The following is a description of a gene set: from publication Ochiai K, Maienschein-Cline M, Simonetti G, Chen J, Rosenthal R, Brink R, Chong AS, Klein U, Dinner AR, Singh H, Sciammas R (PMID 23684984) studied in species Homo sapiens Human Gene Set: GSE46606_UNSTIM_VS_CD40L_IL2_IL5_3DAY_STIMULATED_IRF4_KO_BCELL_DN Temporal analysis of B cell activation in vitro using CD40L and IL-2/4/5 cytokines in wild type Irf4+/+ B cells or in mutant Irf4-/- B cells harboring a tet-inducible allele of Irf4. IRF4 expression was restored, or not, in the Irf4-/- background by culturing in the presence of low or high concentrations of doxycycline. The results provide insight in the role of IRF4 expression levels in coordinating different programs of B cell differentiation. Genes down-regulated in at day 0 B cell IRF4-KO versus CD40L and IL-2 IL-4 IL-5 stimulated at day 3 B cell IRF4-KO., and this is the list of marker genes: TMPRSS12 (NCBI Gene Id 283471), LIPI, TFAM, RRP1B (NCBI Gene Id 23076), CTTNBP2NL, INTS7, RUNX1T1, NFX1, FMR1, DDX10, EFR3A, DICER1, DBR1, FUT4 (fucosyltransferase 4), TRIM69, ITPRID2, ZNF496, CCNT2, TFEC, BOD1, INTS12, PARP12, YBX1, ATF5, MICB, IFIT3, RLIG1, ZCCHC2, KLF11, TRIM47, G3BP1, TBRG4, TRIP13, SLC35F2, AIRIM (NCBI Gene Id 54955), COG6, MMACHC, GCNT2, MREG, MMAA, CERT1 (NCBI Gene Id 10087), ERH, NOL10, LRRC69, LRRC40, CNDP2 (NCBI Gene Id 55748), SLC35A4, KICS2, RPP40, ZNF571, MTX3 (metaxin 3), ICE1, ZNFX1 (zinc finger NFX1-type containing 1), TOP3A, IFI27, RASA1, NEXN, IRF9, ADPRS, DTX3L, OTUD4, IFI35, RRP7A, FHIP2A, AP1AR (NCBI Gene Id 55435), ZNF565, ZNF343, MAK, CEP83, RDM1, ZNF875, PLBD2, TRMT13 (NCBI Gene Id 54618), MKLN1, IFRD2, SNX24, STARD7-AS1, MGAT1, LRRC74B, ZNF268, UBE2E2, PPARGC1B, GMPR, THAP12, DCAF1, DHCR24, KLF16, SAMD9, LINC01364, POLR1A, METTL1, SMG1P1, BIRC6, PGGT1B, IRF2, PHACTR2, MYOF, WDFY1, HERC6, POLK, PEX10, ELOVL2, CYFIP1, NUP50-DT, LINC03006, DNAAF2, RIGI, TMEM144, ZNF37BP, ZNF202, ILF3, MORC2, ZNF782, TXLNGY, NPC2, BORA, C1orf174, CRTAM, DNAJC11, CXCL10, DTNBP1, SNAPC3, PSMD5, HESX1, RPAP3, NEK4, EIF2AK2, EHHADH, MSR1, TMEM140, CIPC, TANGO6, WAC-AS1, SND1-IT1, SAMD13, LGALS3, UBE3D, FEM1B, FAM91A1, DMXL1, DDX55, MYO9B, EIF1AX, ABHD12, ME1, PAM16, RICTOR, TASL, ZNF141, AMDHD2, NUDT15, ISOC2, TAF2, GLMN, IL4I1, STX17, CLCN5, GSPT1, ZNF57, PRADC1, PWWP2A, ZNF736, MIR17HG, AIM2, CBLB, SRFBP1, SMU1 (SMU1 DNA replication regulator and spliceosomal factor), RGL1, SPTA1, MS4A6E, MCM3AP-AS1, MOSPD2, SHFL, FTX, MEST, CDK4, TTL, MOV10, CNOT9, TRA2B, SACS, DNPEP, SCD5, CBR1, RNH1, IFIH1, POU2F1, CIBAR1, COX10, PCGF5, HLA-B, IFIT5, STS, ABHD12B, SHISA5